Given this list of marker genes ABCD1, RNF113A, AARS1, CTSK, ADGRG1, ERCC3, CARS1, PLP1, PTEN, GTF2H5, ERCC2, SOX10, PHGDH, GTF2E2, TARS1, MCOLN1, HSD17B4, MPLKIP, PSAP, here is a description of the gene set: Defective structure and function of myelin sheaths of the white matter of the brain. Cerebral dysmyelination studied in species Homo sapiens Human Gene Set: HP_CEREBRAL_DYSMYELINATION